Given this list of marker genes MFAP4, CYGB, PCAT14, ADA, UMODL1, AGPS, CD200, ENAM (NCBI Gene Id 200), TRBVB, LAIR1, here is a description of the gene set: species: Homo sapiens from publication Hay SB, Ferchen K, Chetal K, Grimes HL, Salomonis N (PMID 30243574) Human Gene Set: HAY_BONE_MARROW_CD34_POS_CLP